Given this list of marker genes GREM1, SIX2, CTNNB1 (catenin beta 1), STAT1, PAX8, SOX9, WNT4, LHX1, GDNF, KIF26B, LGR4, HES5, PKD1 (polycystin 1, transient receptor potential channel interacting, NCBI Gene Id 5310), WNT9B, LIF, SALL1, PKD2, WT1, BMP4, HES1, SMO, SOX8, PAX2, here is a description of the gene set: The process in which the anatomical structures of the metanephric nephron are generated and organized. A metanephric nephron is the functional unit of the metanephros. Human Gene Set: GOBP_METANEPHRIC_NEPHRON_MORPHOGENESIS species: Homo sapiens